Given this list of marker genes ITGAM, APAF1, SMAP1, SLC66A3, ARL6, CDKN3, CASP7, CDK2AP1, COA6, RRM1, LGALS1, LAMTOR5, NDUFV3, PSMA5, MKI67, PRC1, BRCA1, ZFAND5, PRDX1, AP3S1, NFE2, ATP5IF1, CORO1C, PPIB, TMEM50B, CKS1B, BATF, CDC45, S100A10, BTF3, PERP, CENPA, UGCG (UDP-glucose ceramide glucosyltransferase), KLRG1, ABRACL (NCBI Gene Id 58527), CDC25C, MRPL43, CCR2, ATP5PF, NCBP1, IDH1, BBLN, MFSD14B, GLRX, PRRC1, GEM, DCLRE1A, TBCB, FADS1, PDCD1, VPS29, GPD2, NDRG1, ATP6V1A, MRPL27, CD68, MED12L, HDAC1, ANXA1, TMEM165, PRIM2, NDUFV2, CD244, FRG1, KLRC1, ASF1B, COQ3, RNASEH2B, HIKESHI, DBI, DNAJC1, CDC6, CD9, LITAF, IDH3A, DAP, MNS1, GZMA, GTSE1, PSMA4, LACTB2 (NCBI Gene Id 51110), TMED2, GZMK, SRP14, CCDC12, TRAPPC1, ETFB, LMNB1, TCF19, HK2, PRELID1, PTGR1, PRKCB, SNX10 (sorting nexin 10), MEMO1, GABARAPL1, MRPS21, ANXA2, KIF2C, STMN1, F2RL3 (F2R like thrombin or trypsin receptor 3), KCTD9, CSTB, IDE, RACGAP1, ENTPD1, CPT1A, CCNA2, ACYP2, ANXA4, MRE11, CDC20, DHRS1, FXN, TXNDC17, CDK1 (cyclin dependent kinase 1), PSMA2, HMGB2, KIF22, P3H4, SH3BGRL, TWSG1, ADAM8, REEP5, RNF14, CHAF1A, MOCS2, UBL5, KIF11, IRF8, CDCA5, MRPS17, LAMC1, KIF4A, LMAN2, GZMB, YBX3 (Y-box binding protein 3), RSU1, NUSAP1, GDAP2, EZH2, CMC2, COX17, SMDT1, VMP1, SUN1, GNG10, BUB1, CDKN2C, PCLAF, CCNB2, KPNA2, AK3, ENSG00000286190, LAMP2 (lysosomal associated membrane protein 2), CRY1, BAK1, BMAL1, BCL2A1, PPP2R5C, PLK4, TYMS, RRM2, KRTCAP2, IL12RB2, PTPRA, TXN, TOP2A, ITGA4, SLC2A3, ADPRH, PSMD8, NCAPH, REPS1, GNPDA1, ATP6V0E1, CD48, ACSL5, CDK2, MSRB1, MAD2L1, CCNF, S100A4, LAT2, MFHAS1, COMMD2, LYPLA1, DLGAP5, GSN, CHD7, EEF1AKMT1, EMP1, LGALS3, BIRC5, PHF5A, HASPIN, TAB2, DENND5A, TACC3, CARHSP1, here is a description of the gene set: Genes up-regulated in effector CD8 T cells at the peak expansion phase (day 8 after LCMV-Armstrong infection) compared to memory CD8 T cells (day 40+ after LCMV-Armstrong infection). studied in species Homo sapiens Human Gene Set: KAECH_DAY8_EFF_VS_MEMORY_CD8_TCELL_UP from publication Kaech SM, Hemby S, Kersh E, Ahmed R (PMID 12526810) How and when memory T cells form during an immune response are long-standing questions. To better understand memory CD8 T cell development, a time course of gene expression and functional changes in antigen-specific T cells during viral infection was evaluated. The expression of many genes continued to change after viral clearance in accordance with changes in CD8 T cell functional properties. Even though memory cell precursors were present at the peak of the immune response, these cells did not display hallmark functional traits of memory T cells. However, these cells gradually acquired the memory cell qualities of self-renewal and rapid recall to antigen suggesting the model that antigen-specific CD8 T cells progressively differentiate into memory cells following viral infection.